The following is a description of a gene set: Mouse Gene Set: CUI_LANGERHANS_IL1A_RESPONSE_DN Cytokines mediate cell-cell communication in the immune system and represent important therapeutic targets. A myriad of studies have highlighted their central role in immune function, yet we lack a global view of the cellular responses of each immune cell type to each cytokine. To address this gap, the authors created the Immune Dictionary, a compendium of single-cell transcriptomic profiles of more than 17 immune cell types in response to each of 86 cytokines (>1,400 cytokine-cell type combinations) in mouse lymph nodes in vivo. A cytokine-centric view of the dictionary revealed that most cytokines induce highly cell-type-specific responses. For example, the inflammatory cytokine interleukin-1β induces distinct gene programmes in almost every cell type. A cell-type-centric view of the dictionary identified more than 66 cytokine-driven cellular polarization states across immune cell types, including previously uncharacterized states such as an interleukin-18-induced polyfunctional natural killer cell state. studied in species Mus musculus Genes negatively differentially expressed in cell type: Langerhans upon treatment with cytokine: IL-1α in mouse lymph nodes in vivo. from publication Cui A, Huang T, Li S, Ma A, Pérez JL, Sander C, Keskin DB, Wu CJ, Fraenkel E, Hacohen N (PMID 38057668), and this is the list of marker genes: Trim7, Rogdi, Thap2, H2az1, Haus8, Anxa3, Tmem176a, Glipr1, H3f3a, Icosl, Arl5c, Mx1, Sat1, Eno3, Tnfrsf1b, Chka, Man1a, Apol7c, Ftl1, Cyba, Evi2a, Aif1, Abcg1, Hspa1a, Mycbp2, Ankrd33b, Vrk2, Gnl2, Rgs3, Pgap2, Rasa4, Mxd1, Cd52, Tmem150c, H2-M2, Stard7, Relb, Tmem176b, Slc6a6, Nav1, Slc38a2, Rcsd1, Wdr91, Adam23, Hebp1, Laptm5, St8sia1, Cblb, Trio, Hspa1b